The following is a description of a gene set: studied in species Homo sapiens Genes having at least one occurence of the motif CACGTTT in their 3' untranslated region. The motif represents putative target (that is, seed match) of human mature miRNA hsa-miR-302a* (v7.1 miRBase). Human Gene Set: CACGTTT_MIR302A, and this is the list of marker genes: NBEA, PURA, UCHL5, TUT4, CUL2, NREP, ARRDC3, DACH1, PARL, IGF2BP1, EYA2, GSK3B, CPNE4, PUM1, TAF5, OTX2, SRSF10, LEMD3, FAM131B, CNNM3, DOC2A, DPYSL5, FAM168B, LRRC8A, SOBP, PRP4K, ABHD16A, SSBP2, MORF4L1, RAP2C, PTPN9